The following is a description of a gene set: Human Gene Set: GSE21546_WT_VS_SAP1A_KO_AND_ELK1_KO_ANTI_CD3_STIM_DP_THYMOCYTES_DN studied in species Homo sapiens from publication Costello P, Nicolas R, Willoughby J, Wasylyk B, Nordheim A, Treisman R (PMID 20554967) Removal of the transcription factor SAP1a member of the Ternary Complex Factor (TCF) group of transcription factors which in conjunction with Serum Response Factor (SRF) has been shown to have a profound effect on positive selection in the thymus. When another TCF Elk1 is knocked out in mice there is no effect on positive selection unless it is on a Sap1a KO background where the phenotype is very severe. We have stimulated isolated double positive T cells (DPs) with anti-CD3 to mimic positive selection and compared basal and stimulated transcription across the four genotypes to discover the downstream targets of Sap1a involved in positive selection. Genes down-regulated in double positive thymocytes stimulated by anti-CD3: wildtype versus ELK1 and ELK4 knockout., and this is the list of marker genes: SMARCA4, PTGR1, SLAMF6, ZNF483, MPRIP, TTLL11, IRAG2, CCNA2, PARP3 (poly(ADP-ribose) polymerase family member 3), MYBPC2, UBAC2, GLUL, CRIP1, ACP3, UACA, PDS5B, RHOA, TP53I11, PRR15, ZBTB2, RAI14, DNAJC21, RELB, HIVEP3, GFRA1, MREG, TOP2A, EHMT1, ACY3, MROH2A, MYO1C, NIBAN3, IGKC, PPM1E, SLC15A3 (NCBI Gene Id 51296), DDC, DCK, PCMTD1 (NCBI Gene Id 115294), NRF1, GIMAP5, SGK1, FBXL12, MCCC1, UCP2, AFG2B, HIVEP2, FAM53B, CSGALNACT1, ENPP6 (ectonucleotide pyrophosphatase/phosphodiesterase 6), DUBR, CDC25B, TMEM132E, PBXIP1, RAB3IP, BUB3, LRCH1, SMOC1, SEMA3G, ELOF1, PLK1, MPHOSPH8, LEF1, SPEF1, FCRLA, ITPR2, PIF1, PKIG, RRAS2, ISCU, HES5, ABL2, BCAT1, SLAMF7, UBL5, PXK, SGO2, HDDC3, CDKN2C, RXFP1, EIF2AK3, CDKN2D, MTOR, TLR4, BCL7A, TRIM11, GBP2, JCHAIN, C3orf70 (chromosome 3 open reading frame 70), EFHD1, CTNNAL1, FRG1, SNN (stannin), GSTT2, OXR1, FAM193B, RFLNB, TTPAL, ENPEP, SERTAD4, LY6D, SMTNL2, CD38, GPD1L, BUB1B, KMT2E, CENPF, ELOVL6, NABP1, KLHL28, MAGI3, VEGFA, GPAT3, ENSG00000267882, TNFAIP3, PRKCA, TSPAN13 (NCBI Gene Id 27075), TMEM131L, MINDY2, NCAPD2, HASPIN, CCDC38, SLC35F2, SCN4B, PRKCB, TMEM91, ABHD14B, IER5, DDX19A, RRM2B, ZNF821, SAPCD1, CAPSL, DYRK2, PDE3B, RFTN2, ASF1B, ADAM9, ETHE1, SIT1, ATP1B1, KLF7, IRS1, TNFSF10, EBF1, SHB, RAG2, SDC4, GPAM, SLC37A2, E2F2, EDARADD, TMEM263, GIMAP1, CERK, TGFBR2, CACNA2D1, FRYL, N4BP2, RNASE4, ELL3, BMF, CPM, DYNC2H1, UBE2C, PLPP3, PRKD2, ANKFY1, TBC1D17, EPS8, LAMC1 (laminin subunit gamma 1), ZNF143, INPP5A, NDE1, ZAN, ENDOU, IRF4, DESI1, NT5DC3, GTSE1, TEDC1, ADAM19, LIG4, ENTPD1, SIPA1, ZFP69, BMAL1, ENTPD5, CDKN3, PHLPP1, BLNK, KMT2A, FBXL14, KIF23, GFRA2, RPL3L, RSPH9, APBB1, PDE9A, DMTF1